The following is a description of a gene set: from publication Yevshin I, Sharipov R, Kolmykov S, Kondrakhin Y, Kolpakov F (PMID 30445619) Human Gene Set: TASOR_TARGET_GENES species: Homo sapiens Genes containing one or more binding sites for (TASOR) in their promoter regions (TSS -1000,+100 bp) as identified by GTRD version 20.06 ChIP-seq harmonization., and this is the list of marker genes: TUBB, WASF1, MBD4, H2AC11, MUC20-OT1, CWF19L2 (NCBI Gene Id 143884), NDE1, AFF1, USP48, H3C8, SUPT5H (NCBI Gene Id 6829), TOMM7, EIF4B, RBM33-DT, DPH5, PIGK, MAP4K1, AKAP1, PAF1, ANTKMT, P2RX6, TPT1-AS1, DTWD1, H2BC4, TRAPPC5, PYCR1, NCOA5, ETFRF1, CDCA7, NIFK-AS1, RAD52, LINC02482, H2AC17, BAG5, MPG, CIAO3, EED, TFDP1, VAMP8, TPT1, SENP8, ZEB1, H2BC21, DRAM2, CENPBD2P, UTP15, ARHGAP28, OSTC, EEF1G, PZP, RPL32P3, MYO9A, GGCX, RNF7, DDI2, E4F1, H2AC7, ZZEF1, TBC1D23, CNPY4, MPC1-DT, GNL3, RALGAPA1, SELENOF, RHBDF1 (NCBI Gene Id 64733), DLD, PDPR, COA8, FKBP15, PARG, PRPF31, LRRCC1, CDK2AP2, RPL23A, H2AC21, ZC3H15, GTF2IP12, ZNF862, FAF1, PHAF1, TIMM23B, LINC01409, MRFAP1, ITFG1, SLC7A11, IARS1, CHMP4B, WFDC3, ZNHIT6, TMEM69, ANKRA2, COPB1, H3C12, DDIT4, ELP3, H2AC20, KIFBP, GTF2IP20, HAX1, HS2ST1, PREPL, NDUFAB1, ZNF341-AS1, CLEC16A, MED29, NUDT9, ZNF219, PCNX4, DNAAF5, CACUL1, UBR1, PLEC, DCAF8, CNIH2, H2AC6, HAT1, ZMAT2 (NCBI Gene Id 153527), TCEA1, DNAI7, GOLGA7, TXNL1, TSEN2, ABT1, RBM33, EMC8, HIGD2A, CHEK1, RIC8A, METTL13, PARGP1, H2BC18, UTP25, CEPT1, GZF1, CORO7, LINS1, MCTS1, FAAP100, H2BC17, SEPTIN7P14, TAF6, CEP192-DT, MRFAP1L2, CDK8, MPC1 (NCBI Gene Id 51660), NDUFS5, MRFAP1L1, ZC3H10, MKS1, NEURL4, COX4I1, ACO2, RPS16 (ribosomal protein S16), TTI2, BET1L, DGCR6L, H2AC10P, MARF1, AASDH, LEO1, DNTTIP1, MYO19, CRLS1, ASB7, CCDC138, PHKB (phosphorylase kinase regulatory subunit beta), CDC40, DLAT, SNORD42B (small nucleolar RNA, C/D box 42B), PRKAR1B, REXO2, KIAA2013, S100PBP, PIGW, WDR7, RPL32, CCDC184, PKN2, FKTN, GCLM (NCBI Gene Id 2730), HERPUD1, DNAJC19, CZIB-DT, FKTN-AS1, EIF3D, METTL3, TUBE1, BIRC2, IFT122, PITHD1, AHCY, EPRS1, H2BC12, MIR3143, CDK7, SLC3A2, DPH5-DT, BOLA1, C4orf36, CYB5D2, CYCS (cytochrome c, somatic), RIOK2, GUSB, PDPR2P, ZNF330, TAFAZZIN, PSMD8, PHF5A, CHERP, CSNK1G2, PPP5C, C1orf122, DNAJC9-AS1, RPS6KL1, CTNNBL1, MRPS16, NOL6, FAM229B, FAM117B, NSUN5, SRRM2, MCM8-AS1, SLC31A1, H2BC10, SH3BP5L (NCBI Gene Id 80851), LINC01359, EIF3K, CAMKMT, ENSG00000245651, SOX2-OT, NAALADL2, NFKBIA, TPD52L1, CDKN2C, TAF13, CZIB, PBRM1, HCP5, H2BC7, NDST1-AS1, CCDC174, TMTC3, PCNX4-DT, SLC1A5, ZBED3-AS1, PDSS2, H1-10 (NCBI Gene Id 8971), CHAC1 (ChaC glutathione specific gamma-glutamylcyclotransferase 1), PCK2, MIR3124, RNF187, CEP192, ETFDH, NAA30, MZF1, H1-2, MRPL15, H2BC5, UTP14A, SNORD13, ESYT1, ELOA-AS1, TFPT, CEP290, DPY30, RNF111, C4orf46, TIMM23, CNOT11, AXIN2, TBC1D8, CLASP1 (cytoplasmic linker associated protein 1), INHBE, ARID5B, H4C2, ZEB1-AS1, ZBED3, USP54, DNAJA3, LSM4, SUMO1P1, YARS1, H2AC12, ASNS, H2BC11, GPBP1L1, FAM227B, IPO8, PSMB6 (proteasome 20S subunit beta 6), TGDS, TAF5